The following is a description of a gene set: Waddling gait Weakness of the hip girdle and upper thigh muscles, for instance in myopathies, leads to an instability of the pelvis on standing and walking. If the muscles extending the hip joint are affected, the posture in that joint becomes flexed and lumbar lordosis increases. The patients usually have difficulties standing up from a sitting position. Due to weakness in the gluteus medius muscle, the hip on the side of the swinging leg drops with each step (referred to as Trendelenburg sign). The gait appears waddling. The patients frequently attempt to counteract the dropping of the hip on the swinging side by bending the trunk towards the side which is in the stance phase (in the German language literature this is referred to as Duchenne sign). Similar gait patterns can be caused by orthopedic conditions when the origin and the insertion site of the gluteus medius muscle are closer to each other than normal, for instance due to a posttraumatic elevation of the trochanter or pseudarthrosis of the femoral neck. studied in species Homo sapiens Human Gene Set: HP_WADDLING_GAIT, and this is the list of marker genes: HNRNPA1, SLC39A13, BGN, UFSP2, POGZ, CHKB (NCBI Gene Id 1120), TTI1, DPAGT1, SGCB (NCBI Gene Id 6443), MYH2, BICD2 (BICD cargo adaptor 2), SLC34A3, SLC18A3, CANT1, KBTBD13, MORC2, DYM, NOG, NEFL, MYH7, HNRNPA2B1, FHL1, DNAJB6, VCP, IFIH1, LMNA, SGCG (NCBI Gene Id 6445), TPM3, ACBD5 (acyl-CoA binding domain containing 5), COL13A1, TRPV4, LTBP4, DYNC1H1, MATN3, CHAT, GFPT1, SYNE2, COMP, DMD, SCN4A, HACE1, NEFH, NEB, DPM3, MUSK, YY1, POMT1, MMP13, COL9A2, FGD4, TRAPPC11, ANO5, AGRN, COL9A3, AP4M1, ALG14, SYNE1 (spectrin repeat containing nuclear envelope protein 1), LMOD3, CFL2, PREPL, ACTA1, GALNS, POC1A, TPM2, LAMA2, DEAF1, AP4B1, TTN, SLC26A2, FKBP14, SPEG, FKRP, COL10A1, TNNC2, RYR1, MAP3K20, FN1, HACD1, ACAN, SLC5A7, CCN6, GMPPB, TRAPPC10, VAPB, COLQ, SMN1, SMARCAL1, SGCA, HSPG2, ALG2, FLNC, SLC25A1, KLHL41, LAMB2, DOK7, PLEKHG5 (pleckstrin homology and RhoGEF domain containing G5), MBTPS1, COL12A1, FDX2, VAMP1, IDH1, ALPL (alkaline phosphatase, biomineralization associated), SYT2, EMD (emerin), MYO9A, MYPN, COL6A2, BIN1, DSTYK, SLC6A17, SPG7, LRP5, TRIM32, SELENON, TMEM43, PHEX, CHST3, DAG1, SLC34A1, AP4S1, PTH1R, COL2A1, COL9A1, COL6A3, ASAH1, SNAP25, TNNT1, AP4E1, TGFB1, COL6A1 (NCBI Gene Id 1291)